The following is a description of a gene set: from publication Cui A, Huang T, Li S, Ma A, Pérez JL, Sander C, Keskin DB, Wu CJ, Fraenkel E, Hacohen N (PMID 38057668) Mouse Gene Set: CUI_TREG_NOGGIN_RESPONSE_DN Cytokines mediate cell-cell communication in the immune system and represent important therapeutic targets. A myriad of studies have highlighted their central role in immune function, yet we lack a global view of the cellular responses of each immune cell type to each cytokine. To address this gap, the authors created the Immune Dictionary, a compendium of single-cell transcriptomic profiles of more than 17 immune cell types in response to each of 86 cytokines (>1,400 cytokine-cell type combinations) in mouse lymph nodes in vivo. A cytokine-centric view of the dictionary revealed that most cytokines induce highly cell-type-specific responses. For example, the inflammatory cytokine interleukin-1β induces distinct gene programmes in almost every cell type. A cell-type-centric view of the dictionary identified more than 66 cytokine-driven cellular polarization states across immune cell types, including previously uncharacterized states such as an interleukin-18-induced polyfunctional natural killer cell state. species: Mus musculus Genes negatively differentially expressed in cell type: Treg upon treatment with cytokine: Noggin in mouse lymph nodes in vivo., and this is the list of marker genes: Uba52, Dusp1, Fos, Rgs2, Junb